The following is a description of a gene set: Mouse Gene Set: GOBP_RE_ENTRY_INTO_MITOTIC_CELL_CYCLE species: Mus musculus The resumption of the mitotic cell division cycle by cells that were in a quiescent or other non-dividing state., and this is the list of marker genes: Myc, Ccnf, Ccnd1, Ndp, Gsk3b